Given this list of marker genes FSHR, CLN3 (CLN3 lysosomal/endosomal transmembrane protein, battenin), AQP1, AQP11, SCTR, AQP4 (aquaporin 4), SCT, here is a description of the gene set: A homeostatic process involved in the maintenance of a steady state level of water within a cell. species: Homo sapiens Human Gene Set: GOBP_INTRACELLULAR_WATER_HOMEOSTASIS